Given this list of marker genes CCN5, LTBP1, IGFBP1, IGFBP2, IGFBP6, CCN3, HTRA1, IGFBP5, CCN1, CCN2, IGFBP7, IGFBP3, here is a description of the gene set: IGFBPs. studied in species Homo sapiens Human Gene Set: MODULE_190